The following is a description of a gene set: studied in species Homo sapiens from publication Yevshin I, Sharipov R, Kolmykov S, Kondrakhin Y, Kolpakov F (PMID 30445619) Genes containing one or more binding sites for (SNAPC2) in their promoter regions (TSS -1000,+100 bp) as identified by GTRD version 20.06 ChIP-seq harmonization. Human Gene Set: SNAPC2_TARGET_GENES, and this is the list of marker genes: MAF1, RNU6ATAC, RNU12, CLASP1, RNU1-1, POLDIP3, RNU6-8, RNU1-2, RNU4-2, ERCC1, RNU4ATAC, RNU5E-1, RNU5E-6P